The following is a description of a gene set: studied in species Homo sapiens Human Gene Set: GOBP_EXTRACELLULAR_MATRIX_CONSTITUENT_SECRETION The controlled release of molecules that form the extracellular matrix, including carbohydrates and glycoproteins by a cell., and this is the list of marker genes: CREB3L1, NOTCH1, RGCC, BMP2, PRICKLE1, TMEM38B, ADTRP, TNFRSF1B, TNFRSF1A (TNF receptor superfamily member 1A), IER3IP1, RIC1